Given this list of marker genes SLC1A2, TMEM260, LTN1, GYPB, SMIM17, MAGI1, PRLR, SLC31A2, UBE3D, DVL3 (NCBI Gene Id 1857), LHFPL6, SMIM43, ALG10B, SESTD1, SEMA3F, GPC6, SRSF10, ZNF69, RSBN1, EAF1, RNPEP, GAS6, FZD3, PLCB4, TPRX1, NR2C2, PITPNC1, SRD5A1, DSC1, PHKA1, IKZF1, AHR, ACTL6A, GNG12, PABIR2, STK39, RUBCNL, NOC3L, ZNF260, USF3, SLC2A12, CCDC126, KRTAP9-4, MAPK8, MAP3K19, SETD7, SP4, SERAC1 (serine active site containing 1), NIPA1, VNN1, SMARCA1, RAD51B, DOCK4, CTDSPL2, SLC36A4, IPO7 (importin 7), GALNT15, ATP8A2, FABP2, DBX2, PEAK1, PCDH15, TMCC3, TCP1, NISCH, MAP7D3, COMMD10, CWC25, SYNPO2, PRRC1, COL4A3, SHQ1, ATP11A, RPH3A, P2RY14, PRDM15, C8orf34, ABCC9, FYB1, PDK4, YWHAZ, BCL11B, ATG3, MOB3B, CAMK2N1, DDHD1, CST11, PPARGC1A, COL4A6, ERC2, KRTAP9-8, PAPOLB, PIAS2, MYO6, RBM28, JADE3, RABGAP1L, XRCC5, TPGS2, PRRC2C, BACH1, MCOLN2, ARMC2 (armadillo repeat containing 2), PHLDB2, SGIP1, ITGBL1, EMP1, NAALADL2, OPRK1, KHDRBS2, DAAM2, CALHM5, CHAF1A, SLC4A4, MKLN1, HTR4, ISCA1, STAG2, HAS2, RNLS, BCAT1, CEACAM7, EN1, SLFN12, PET117, CCDC191, SLC35G1, TRIM22, CCSER1, CNOT9, NSMAF, MARCHF4, PALS1, OXLD1, PRCD, PTPN4, SLC25A17, RPS6KL1, EPB41L2, CSRNP2, KCNB1, HACE1, AQP4, ABL2, SH3GLB1, ADAMTS3, ABCA13, AGMO, N4BP2L2, KAT6A, ASTN2, FAM120A, NRN1, UBXN2B, LPP, NEK7, PSMD5, MOB1B (MOB kinase activator 1B, NCBI Gene Id 92597), FBXL3, COL19A1, VPS54, MGP, MMRN1, PPP3R1, MTCL2, KMT2A, TMEM47, SPAG9, TRIO, COX15, DGKE, KRTAP9-2, MROH9 (maestro heat like repeat family member 9), PUS3, CDK12, JCHAIN, KLHL29 (kelch like family member 29), GYPE, SET, PXN, C21orf91, NOTCH2, PAG1, ETV1, PHLPP2, DGKH, ZMAT3, PJA2, FREM2 (NCBI Gene Id 341640), DLG3, LYVE1, GRIN2A, KCNA1, KLHL42, PDIA3, GOLGA6L4, TEX55, SLC25A36, NOVA1, RGS5, STK10, KCNV1, ARHGAP20, TACC2, CLOCK, ATF6, VPS26A, F5, ATP2C1, PPP3CA, CTCFL, BEND4 (NCBI Gene Id 389206), WDR12, MAP3K2, AGO4, TRH, C2CD2L, NTRK2, TRNT1, FAM199X, ZNF641, MYSM1, ST8SIA1, CAP1 (NCBI Gene Id 10487), VCPIP1, LRCH2, ABCC5, A1CF, ACO1, CLASP2, TBL1XR1, UBQLN1, SMIM21, LYSMD2 (NCBI Gene Id 256586), RFX7, TRIM33, GALNT13, PATZ1, PIK3AP1, EFHD1 (NCBI Gene Id 80716), SMC4, CA2, TJP1, KCNN3, PDPK1, C1RL, CD84, NUDT4, SPTY2D1, PTCD3, CHL1, CXCL6, PAPOLG, SPRY3, GRM6, NIPSNAP3B, DNAAF6, PALM2AKAP2, TREM1, ZBTB20, PALS2, here is a description of the gene set: from publication Chen Y, Wang X (PMID 31504780) Genes predicted to be targets of miRBase v22 microRNA hsa-miR-3123 in miRDB v6.0 with MirTarget v4 prediction scores > 80 (high confidence targets). Human Gene Set: MIR3123 species: Homo sapiens